The following is a description of a gene set: species: Mus musculus Any process that results in a change in state or activity of a cell (in terms of movement, secretion, enzyme production, gene expression, etc.) as a result of a lipid stimulus. Mouse Gene Set: GOBP_CELLULAR_RESPONSE_TO_LIPID, and this is the list of marker genes: Pten, Wnt5a, Pax2, Il6, Syk, Sgms1, Ticam1, Ltk, Mir205, Foxa1, Mir155, Ptpn11, Ugt1a6b, Mir381, Lancl2, Hoxa2, Capn2 (NCBI Gene Id 98318), Kdm3a, Cd55, Ar, Defa31, Plcb1, Gprin3, Mir146b, Efnb2, Tescl, Phc1 (polyhomeotic 1), Cx3cr1, Gbp6, Pias2, Mir125a, Ahr, Tnfsf4, Ptger2, Ednrb (NCBI Gene Id 13618), Ptger4, Klf4, Abl2, Cd80, Btg2, Cyp24a1, Mir200c, Mir184, Mir98, Pagr1a, Chmp5, Etnppl, Esrra, Arid5a, Mir182, Yap1, Nlrp3, Bdnf, Agtr1b, Il17a, Cps1, Adipor2, Mir467d, Fdx1, Mir7b, Snw1, Mn1, Pid1, Dgkq, Mir323, Mir224, Mup2, Mir409, Hsf1, Twf2, Ppbp, Gdap1, Mir598, Mir146, Msn, Inhbb, Prmt2, Mrc1, Adam9, Mir199a-1, Pf4, Ltf, Star, Cxcl2, Dnaaf4, Yes1, Lyn, Rora, Kcnk2, Mef2c, Agtr2, Ccdc62, Mstn, Ucp1, Eif4ebp1, Mir30c-1, Nfkb1, Ruvbl2, Cd36, Vps18, Defa37, Defa38, Ptafr, Ephb2, Nfkbia, Cnot9, Il36b, Nr3c1, Il12b, Brinp1, Trim12c, H2az1, Akr1c19, Add1 (NCBI Gene Id 11518), Msx2, Cyp26b1, Cd180, Plscr4, Trim55, Mup3, Ufl1, Mir511, Kdm6a, Igf1, Cd14, Tead1, Mir433, Cd300lb, Trim24, Hadhb, Src, Nr1h3, Ppm1e, Cldn1, Ang4 (angiogenin, ribonuclease A family, member 4), Gbp2b, Pdk4, Mir30d, Mir142 (microRNA 142), Arid1a, Gnas, Ptpn22 (NCBI Gene Id 19260), Rarg, Rest, P2ry6, Cmpk2, Srebf1, Trem2, Vps11, Rorb, Sfrp1, Kcnmb1, Ufm1, Ctsg, Irs1, Cpt1a (NCBI Gene Id 225890), Ces1g, Fbp1, Ramp3, Insig2, Akr1c12, Slc6a4, Hdac8, Zfp747, Mir30c-2, Hmgcs2, Mir194-2, Pck1, Prkd1, Slc2a2, Eif4e, Nuggc, Map2k3 (mitogen-activated protein kinase kinase 3), Aicda, Prdx2, Litaf, Mir181c, Sstr5, Ldoc1, Mapk8, Ly86, Rbfox2, Mir29b-1 (NCBI Gene Id 387223), Slc12a2, Ddx17 (NCBI Gene Id 97974), Bcl10, Carm1, Kdm4c, Pycard, Tnip3, Il36a (interleukin 36A), Park7, Tnf (NCBI Gene Id 21926), Pim1, Defa17, Brinp3, Ddrgk1, Ptgdr, Myod1, Atp5f1a, Csf3, Gdnf, Adamts13, Il1b, Ogt, Cdc73, Mir107, Spp1, Ace, AY761185, Mir26b (microRNA 26b), Nedd4, Ptgs2, Sstr2, Insig1, Smo, Abcb1a, Prpf8, Esrrb, Cnot1, Rplp0, Alox12, Mirlet7a-2, Padi2, Stra8, Akr1c18, Casr, Ghrhr, Zfp747l1, Ncoa1, Penk, Gramd1c, Cxcl5, Lats1, Cry2, Errfi1, B2m, Nos2, Cactin, Cebpb, Il10, Xrcc5, Ptpn6, Kat5, Ctr9, Defa3, Calcoco1, Safb, Zfp764, Mup11, Epha3, Pgr, Tspo, Map4k1, Cnot2, Trerf1, Kdm5d, Mir194-1, Hmgb2, Gfer, Mapk1, Trib1, Irak2, Nr2c2 (NCBI Gene Id 22026), Ndufa13, Crebrf, Mir293, Tnc, Gramd1a, Ufsp2, Foxo1, Uba5, Ptch1, Lpl, Epsti1, Phex, Ldlr, Mir383, Mir21a, Trim68, Foxo3, Serpine1, Kmo, Mapk3, Ankrd1, Cxcl9, Zfp683, Mgarp, Mir24-1, Ccl28, Zfp764l1, Irgm2, Usp26, Cyp27b1, Ces1d, Ubr5, Fkbp4, Ass1, Defa42, Mir494, Zfp703, Zfp36, Ugt1a1, Rwdd1, Casp1, Cry1, Smarcd1, Prkce, Elk1, Dgat2, Git1, Pck2 (phosphoenolpyruvate carboxykinase 2 (mitochondrial)), Gpr155, Mir23b, Kcnk4, Cxcl16, Ywhah, Nr1d1, Bcl2l2, Irak3, Casp7, Abca1, Il18, Shpk, Abl1, Skp2, Ccna2, Cxcl13, Klrk1 (killer cell lectin-like receptor subfamily K, member 1), Htra2, Defa20, Zfp36l2, Pou4f2, Mir16-2, Zbtb7a (NCBI Gene Id 71606), Foxp1, Prkaa1, Malt1, Trim30b, Hdac1 (NCBI Gene Id 630524), Map2k7, Vim, Mlc1, Fos, Tbx2, Mir342, Gper1, Smyd3, Ces1c, Ces1b, Dab2ip, Inhba, Irak1, Brinp2, Jak2, Snai2, Fech, Ly96, Trip4, Bad, Lmo3, Gbp2, Tut4, Cyp1b1, Ntrk2, Ces1h, Mmp8, Zc3h12a, Abcb4, Defa26, Rnf4, Tbx1, Zfp366, Cx3cl1, Scimp, Irak4, Cdk4, Tnip1, Mir199a-2, Mup1 (major urinary protein 1), Fes, Cyp26a1, Klf9, Tnfaip3, Ppara, Rnf6, Cnot3, Creb1, Strn3, Ccl2, Foxh1, Defa22, Ccl27a, Raet1d, Slc7a5, Ptges3, Defb21, Dnm1l, Prkca, Anxa1, Defa23, Sox10, Gjb2, Mir147, Akt1, Defa24, Ncl, Ncor2, Pak1, Havcr2, Plscr2, Rxra, Ces1a, Nr0b1, Myd88, Edn1, Srarp, Pde3a, Zfp36l1, Sstr3, Ppard, Med1, Mir150, Rxrg, Akap8 (NCBI Gene Id 67462), Il36g, Mmp2, Mir7-1, Smarca4, Ffar2, Plcg2, Mir217, Paf1, Ffar3, Acod1, Lbh (NCBI Gene Id 77889), Lcor, Ccr5, Esr1, Defa30, Ret, Tbxa2r, Ncoa3, Gnai1, Nr3c2 (nuclear receptor subfamily 3, group C, member 2), Casp9, Heyl, Sphk2, Gsk3b, Acaca, Ankk1, Tmf1, Mir223, Mir486, Mir202 (NCBI Gene Id 387198), Igtp, Scgb2a2, Pde4d, Mir181b-2, Egfr, Tead2, Crhbp, Irgm1, Mir139, Drd2 (dopamine receptor D2), Mup5, Pdcd4, Bpi, Adcy5, Mir672, Pdcd1lg2, Efna5, Slc39a9, Dynapl1, Vps54, Nfkbiz, Fgf23, Camp, Lilrb4a, Ugt1a6a, Slc5a5, Npc1, Cdk19, Kif18a, Meiosin, Zmiz1, Il36rn, Grip1, Nfatc4, Trim30c (NCBI Gene Id 633513), Trim12a, Ptger3, Tnfrsf1b, Calr, Kmt2d, Il1a, Bmal1, Spi1, Tgfb1, Ripk2, Lbp, Mir181a-2, Aldh1a2, Or51e2, Rps6kb1, Mapk14, Atp1a1, Esrrg, Ces1f, Defa39, Itga2, Ddit4, Cd55b, Rhoa, Sirpa, Clock, Oaz1, Ddx5, Abhd2, Krt13, Npas4, Hmgb1, Taf7, Plscr1, Dynap, Cftr, Hnrnpd, Ncor1, Defa21, Gjb3, Lrp8, Ptgfr, Gh, Sox9, Gstp1, Bmi1, Pde2a, Ppp1r9b (NCBI Gene Id 217124), Tlr4, Il12a, Agtr1a, Cav3, Spon2, Defa29 (defensin, alpha, 29), Pde4b, Rnf14, Mir501, Nfkbib, Nfe2l1, Sstr4, Cyp7b1, Snhg20, Trim30d, Epha5, Axin2, Mif, Fam107a, Defa5, Cd86, Defa41, Wbp2, Cebpe, Mir26a-2, Trim41, Gramd1b, Bmp4, Sash1, Akap13, Mir3099, Rara, Xbp1, Nfkbil1, Cd274, Ifng, Dnaja1, Adcy1, Dab2, Il1f10, Defa25, Mettl21c, Pdia3, Rhox13, Selenos, Lpar1, Nrip1, Atp1a2, Adcy3, Ghsr, Axl, Fshr, Ube3a, Uri1, Pax6, Nr1h4, Mir431, Bmp6, Mir193a, Zdhhc7, Tcf21, Aqp1 (aquaporin 1), Id3, Gbp10, Nod2, Atm, Mir210, Mir500, Adcy8, Scarb1, Lep, Mirlet7g, Ifnb1, Mir26a-1, Akr1c13, Mir350, Dag1, Myog, Tesc (tescalcin), Stap1, Isl1, Hnrnpu, Scnn1g, Cst11, Sbno2, Mir7-2, Mir181a-1, Tfpi, Ptk7, Rorc, Gsk3a, Hand2, Plaa, Mir29b-2, Adcy2, Defa40, Safb2, Daxx, Plscr3, Brca1, Mir30b, Nkx3-1, Cr2, Ptk6, Hmga2, Tifab, Upf1, Cxcl10, Phb2, Hnrnpk, Per1, Aifm1, Fcgr4, Traf6, Hoxa1, Ranbp1 (NCBI Gene Id 19385), Tnip2, mt-Nd3, Trim63, Gfi1, Tlr9, Pdk3, Bcr, Gbp5, Adam15, Halr1, Gch1, Mir425, Pou4f1, Scnn1a, Mup4, Mir24-2, Rock2, Mir10a, Fbxo32 (F-box protein 32), Ces1e, Mir29a, Mir484, Prkaa2, Irf3, Cd84, Vdr, T, Gpbar1, Fam210b, Scnn1b, Mir15a, Cxcl15, Shq1, Sstr1, Trim30a, Adcy6, Defa34, Ube2l3, Sva, P2ry4, Pabpn1, Sirt1, Mtdh (metadherin), Defa28, Crh, Mir27a, Defa35, Phb1, Kank2, Lrp6, Parp1, Irf8, Ncoa2, Ticam2, Osr1, Ep300, Cd68, Sgk1, Rela, Ppargc1b, Mgst1, Gpld1, Serpinf1, Ppp5c, Rxrb, Cd6, Col1a1, Osbpl7, Gata1, Stat1, Ptk2b, Defa2, Esr2, Trp63, Gbp3, Trim5, Cyp7a1, Hes1, Nodal (NCBI Gene Id 21792), Cfh, Stc1, Nos3, Mir345, Mir140, Adcyap1